The following is a description of a gene set: studied in species Homo sapiens Human Gene Set: AGTCTTA_MIR499 Genes having at least one occurence of the motif AGTCTTA in their 3' untranslated region. The motif represents putative target (that is, seed match) of human mature miRNA hsa-miR-499 (v7.1 miRBase)., and this is the list of marker genes: IRF2BPL, ENPP2, UBE2NL, RAB5C, MARCKS, RALYL, UBN1, MYB, FAM131B, ZNF518B, EML4, AEBP2, ZNF655, WTAP, PTBP3, SPTSSB, HIC2, ARHGAP12, PPP3CA, RNF44, PTBP2, ESRRG, FOXN2, SOX6, SOX11, ZBTB10, TMED9, AGO4, ZEB2, LRCH2, DDX1, VGLL2, DGCR8, KLHL42, LIN28B (NCBI Gene Id 389421), UBE2V2, KIF3C, H2AZ1, PLAG1, MPPED2, AZIN2, MYEF2, SDC2, SOX5, EDAR, CELF2, UBE2V1, ADAM10, ARID2, UBE2E1, MAPK6, RYBP, FOXO4, TOP1 (NCBI Gene Id 7150), TRAM1, SEC11A, PEDS1-UBE2V1, NOL4L, RSBN1, ZNF711, CHRFAM7A (NCBI Gene Id 89832), HNRNPC, SINHCAF, RCN2, KPNA3, NAV2, RIC8B, QKI, VCPIP1, TESK2, RNF220, MECP2, ARGLU1, REEP1, NOVA1, CFL2, PDCD4